The following is a description of a gene set: Mouse Gene Set: GOCC_TRANS_GOLGI_NETWORK The network of interconnected tubular and cisternal structures located within the Golgi apparatus on the side distal to the endoplasmic reticulum, from which secretory vesicles emerge. The trans-Golgi network is important in the later stages of protein secretion where it is thought to play a key role in the sorting and targeting of secreted proteins to the correct destination. studied in species Mus musculus, and this is the list of marker genes: Chst5, Lrrk2, Atp8b2, Marchf9, Bpnt2, Tas2r118 (taste receptor, type 2, member 118), Ap3b2, Pick1, Arl1, Bicd1, Coro7, Elapor1, Bsn (NCBI Gene Id 12217), Pcsk5, Arl5a, Ms4a7, Postn, Slc24a5, Atp9b, Arfgef2, Tmem165, Arl5c, Furin, Nmnat2, Adam10, Atp9a, Dop1a (NCBI Gene Id 97520), Cnst, Ap4s1, Tbc1d23, Rab13, Slc11a2, Cimap3, Rac1, Atp8a2, Arfrp1, Ap1b1, Tjap1, Fut4, Kif13a, Stx4a, Vps53, Azin2, Tgoln1, Gba1, Plekha3, Wdr11, Slc39a9, Clasp2, Ap1s1, Lamp2, Caln1, Snx9, Stx16, Gga2, Cd2ap, Lrba (LPS-responsive beige-like anchor), Wipi1, Atxn2 (NCBI Gene Id 320857), Cln3, Pheta1, Arfip1, Slc9a7, Nbea, Gcnt1, Vamp5, Cpd, Grn, Slc35b3, AU040320 (NCBI Gene Id 100317), Tpst2, Asap1, Nucb1, Lgr5, Slc9a8, Rab7b, Plekhj1, Atp2c1, Pacsin3, Slc30a5, Prepl, Ap1g1, Vps13b (NCBI Gene Id 97991), Dnaaf6, Flna, Arl5b, Plekha8, Yipf7, Rab11a, Clba1, Pcsk7, Ccdc91, 5730455P16Rik, Stx8, Pacsin1, Dnaaf6rt, Trappc6b, Ap1s2, Scamp4, Smpd4, Nsg2, Aftph (NCBI Gene Id 75762), Ccdc186, Mme, Rab21, Atp2c2, Marchf4, Crhr1, Atp8b5, Arf1, Pik3c2a, Ap4m1, Mlana, Ece2, Yipf2, Yipf1, Pam, Relch, Slc2a4, Fut7, Ift88, Rbfox1, Tgfbi, Pclo, Atg9a, Inpp5k, Vps54, Rab30 (NCBI Gene Id 75985), M6pr (NCBI Gene Id 17113), Llgl1, Scamp2, Pi4k2b, Tgfb2 (NCBI Gene Id 98738), Scamp3, Bace1, Klhl20, Rab14, Fcmr, Stx6, Atp8b1, Myo1b, Baiap3, Yipf5, Atp8a1, Cracr2a, Ap1g2, Chst4, Arfip2, Rgs20, Clvs2 (clavesin 2), Gga1, Vps51, Tmem230, Arfgef1 (NCBI Gene Id 226334), Pcsk4, Chid1, Ap4b1, Scamp1, Snap25, Clvs1, Gpr108, Atp8b4, Prkd1, Bok, Phaf1, Atp7b, Atp8b3, Osbp, Dop1b, Hook2, Ap4e1, Ndst1, Ap1s3, Ap1m2, Gsap, Chac1, Slc35b2, Golph3, Ocrl, Wls, Ntsr2, Atg9b, Vamp4, Slc10a7, Myo18a, Lap3, Gga3, Rab32, Becn1, Slc66a2, Optn, Mmp24, Ms4a6b (membrane-spanning 4-domains, subfamily A, member 6B), Fam91a1, Arap1, Fut9, Rab38, Vamp2, Ms4a6c, Aqp2, Gbf1, Ap3s2, Chst2, Cltb, Gper1, Rab29, Car4, Pcsk1n, Ms4a6d, Gh, Eipr1, Rab11fip3, Golga1, Trappc6a, Bace2, Birc6 (baculoviral IAP repeat-containing 6), Scoc, Pld4, Trappc9, Ap3d1 (NCBI Gene Id 11776), Rab31, Rab10, Golt1a, Clip3, Marchf1, Plod3, Rab6a, Dpy30, Slc30a6, Dennd5a, Bet1l, Pi4k2a (NCBI Gene Id 84095), Plpp3, Gnas (NCBI Gene Id 78290), Tepsin, Yipf4, St3gal1, Pcsk1, Cdh1, Tmem79, Pheta2, Cby1, Nsg1, Golph3l, Cabp7, Pacsin2, Ap1m1, Atp7a, Sorl1, Tpst1, Ap3s1, Syt11, Sys1, Igf2r, Syt17, Scamp5, Yipf6, Gcc2, Dnm2, Ap3b1